The following is a description of a gene set: A process in which nutrients are taken up from the contents of the intestine. species: Mus musculus Mouse Gene Set: GOBP_INTESTINAL_ABSORPTION, and this is the list of marker genes: Slco1a5, Lima1, Cd36, Acat2, Pls1, Apoa4, Kcnq1, Epb41, Ldlr, Fabp1, Apoa2, Pnlip, Tjp2, Slc26a6, F11r, Enpp7, Cldn2, Slc5a1, Hamp, Vil1, Cldn15, Cyp8b1, Prap1, Hamp2, Abcg2, Npc1l1 (NPC1 like intracellular cholesterol transporter 1), Ugcg, Fabp2, Apoa1, Abcb1a, Ireb2, Npc1, Dgat1 (diacylglycerol O-acyltransferase 1), Cel, Vdr, Abcg5, Gcnt3, Heph, Mogat2, Abcg8, Lep, Ezr, Aco1, Scarb1, Lpcat3, Isx